The following is a description of a gene set: species: Homo sapiens Human Gene Set: GOMF_DYNEIN_LIGHT_CHAIN_BINDING Binding to a light chain of the dynein complex., and this is the list of marker genes: DYNC1I2, DYNC2I1, DYNC1I1, DNAI2, HOOK3, DNAI4, DYNC2I2, DNAI1, DNAI3